Given this list of marker genes Pex12, Pex7, Lonp2, Pex5l (peroxisomal biogenesis factor 5-like), Usp9x, Pex1, Pex14, Pex26, Pex2, Pex16, Pex13, Pex5, Pex6, Trim37, Pex10, here is a description of the gene set: Mouse Gene Set: GOBP_PROTEIN_IMPORT_INTO_PEROXISOME_MATRIX studied in species Mus musculus The import of proteins into the peroxisomal matrix. A peroxisome targeting signal (PTS) binds to a soluble receptor protein in the cytosol, and the resulting complex then binds to a receptor protein in the peroxisome membrane and is imported. The cargo protein is then released into the peroxisome matrix.